The following is a description of a gene set: Mouse Gene Set: HALLMARK_HEME_METABOLISM Mouse genes annotated to HALLMARK_HEME_METABOLISM based on orthology mappings provided by the Alliance Genome Consortium from publication Howe DG, Blake JA, Bradford YM, Bult CJ, Calvi BR, Engel SR, Kadin JA, Kaufman TC, Kishore R, Laulederkind SJF, Lewis SE, Moxon SAT, Richardson JE, Smith C (PMID 30224793) studied in species Mus musculus, and this is the list of marker genes: Tfrc, Slc22a4, Nfe2l1, Gmps, Igsf3 (NCBI Gene Id 78908), Agpat4, Hagh, Tspo2, Btrc, Selenbp1, Tal1, Klf3, Map2k3, Daam1, Fbxo7, Car2 (carbonic anhydrase 2), Trim58, Gata1, Dcaf10, Ackr1, Usp15, Slc7a11, Tns1 (NCBI Gene Id 98418), Ppox, Dmtn, Foxj2, Tnrc6b, Bsg, Pgls, E2f2, Epor, Urod, Tcea1, Add2, Ppp2r5b, Hbq1b (hemoglobin, theta 1B), Lamp2, Ucp2, Aldh6a1, Rnf123, Slc4a1, Slc30a1, P4ha2 (procollagen-proline, 2-oxoglutarate 4-dioxygenase (proline 4-hydroxylase), alpha II polypeptide), Marchf2, Cdr2 (cerebellar degeneration-related 2), Sptb, Ctsb, Rbm38, Atg4a, Slc6a8, Hmbs, Ahsp, Tent5c, Sec14l1, Dcun1d1, Ftcd, Cdc27, Lpin2, Ncoa4, Adipor1, Snca, Acp5, Ezh1, Slc10a3, Slc11a2, Bcam, Fbxo9, Uros, Epb42, Cir1, Spta1, Rnf19a, Nek7, Ubac1, Rbm5, Hdgf, Mfhas1, Mkrn1, Tyr, Psmd9, Pcx, Ctns, Bpgm, Nudt4, Sidt2, Blvra, Bmp2k, Rhag, Tspan5, Osbp2, Rcl1, Tmem9b, Ranbp10, Minpp1, Smox, Arhgef12, Abcg2 (ATP binding cassette subfamily G member 2 (Junior blood group)), Mxi1, Fech, Arl2bp, Slc2a1, Icam4, Btg2, Vezf1, Ermap, Ccdc28a, Cat, Xk, Trak2, Ank1, Ypel5, Htra2, Cpox, Sdcbp, Myl4, Synj1, Foxo3, Slc6a9, Alad, Gypc, Fbxo34, Aqp3, Kel, Endod1, Mark3, Gclc, Aldh1l1, Hebp1, Glrx5 (glutaredoxin 5), Blvrb, Pdzk1ip1, Klf1 (NCBI Gene Id 17953), Asns, Trim10, Abcb6, Gde1, Picalm, H1f0, Top1, Ell2, Gapvd1, Dcaf11, Eif2ak1, C3, Gclm, Mgst3, Ctse, Lmo2, Nfe2, Slc30a10, Mpp1, Rhd, Khnyn, Car1, Rap1gap, Prdx2, Alas2, Riok3, Lrp10, Mboat2, AK157302, Marchf8, Tfdp2, Mocos, Htatip2, Kdm7a, Xpo7, Fn3k, Ccnd3, Tmcc2, Atp6v0a1, Pigq (NCBI Gene Id 23889), Clcn3, Narf, Cast, Slc66a2, Optn, Slc25a38, Mospd1, Kat2b, Hba-x, Add1, Rad23a, Bnip3l, Bach1, Nnt (nicotinamide nucleotide transhydrogenase), Epb41, Nr3c1, Acsl6